Given this list of marker genes Brdt, Slc25a31, Dmrtc2, Ddx4, Tdrd9, Btbd18, Meiob, Rpl10l, Meioc, Hspa2, Ing2, Trip13, Siah1a, Rec8, Ubb, Foxj3, Ubr2, Mei1, Zscan21, Rad51c, Mov10l1, Foxj2, Hsf2bp (NCBI Gene Id 74377), Dnmt3l, Dmc1, Brca2, Spo11, Brme1, Mybl1, here is a description of the gene set: Mouse Gene Set: GOBP_MALE_MEIOSIS_I species: Mus musculus A cell cycle process comprising the steps by which a cell progresses through male meiosis I, the first meiotic division in the male germline.